Given this list of marker genes Atf4, Sp7, Runx2, Jun, Msx1, Dlx3, Msx2, Nfatc1, Txlng, Dlx5, Ctnnb1, Fos, Jund, Fosl2, here is a description of the gene set: Mouse Gene Set: ZAIDI_OSTEOBLAST_TRANSCRIPTION_FACTORS An assortment of osteoblast transcriptional regulators. The use of genetically manipulated mouse models, gene and protein discovery and the cataloguing of genetic mutations have each allowed us to obtain new insights into skeletal morphogenesis and remodeling. These techniques have made it possible to identify molecules that are obligatory for specific cellular functions, and to exploit these molecules for therapeutic purposes. New insights into the pathophysiology of diseases have also enabled us to understand molecular defects in a way that was not possible a decade ago. This review summarizes our current understanding of the carefully orchestrated cross-talk between cells of the bone marrow and between bone cells and the brain through which bone is constantly remodeled during adult life. It also highlights molecular aberrations that cause bone cells to become dysfunctional, as well as therapeutic options and opportunities to counteract skeletal loss. species: Mus musculus from publication Zaidi M (PMID 17618270)